Given this list of marker genes CANX, TACC1, ARNT, DSCAML1, PTPN12, PRTG, ELOVL3, ZIC2, CKS1B, DNAJA2, MORF4L2, DPYSL3, MMD, PRRG1, SRSF7, DMWD, ELOVL5, NEXMIF, ZNRF2, ATP10A, NAALADL2, DENND6A, FOXJ3, NBEA, ANKRD50, SIPA1L3, NSG2, ZZZ3, ARHGAP5, GPRC6A, LMO1, SHTN1, JAKMIP2, HAPSTR1, H3-3B, NF2, NHLH2, ACACA (NCBI Gene Id 31), NUTF2, GRIK2, SYNE2, WDR44, MYLK4, POU3F2, UBP1, JUND (NCBI Gene Id 3727), HTRA1, ADAMTS6, NADK, PCOLCE, YTHDF2, EIF5A2, NEUROD1, FBXO11, SZRD1, H3-5 (NCBI Gene Id 440093), STAC2, FUT8, H3-3A, CLK1, WAPL, SON, RBM4B, CACNA1C, SLITRK2, AGO4, BEND4, IGF2BP1, FGFR2 (NCBI Gene Id 2263), C5orf24 (chromosome 5 open reading frame 24), ELF2, PPP1R21, KMT2A, BMPR2 (NCBI Gene Id 659), NOVA1, PCSK1, ADAM10, RNF20, DMD (NCBI Gene Id 548327), CLTA, TACC2, RB1CC1 (RB1 inducible coiled-coil 1), UBFD1, OGT, SP4, ADAMTSL3 (ADAMTS like 3), SLC26A3, ARID4B, ELP1, PHOX2B, CYSTM1, OSBPL6, PRP4K, SMARCE1 (NCBI Gene Id 6605), SETD7, SZT2, RAP1B, EGR3, TAC1, ARHGEF17, LRRC19, LUC7L3, TLNRD1, PRICKLE2, ZNF207, BHLHE40, HAS2, CDK12, WWC2, ANKHD1, CCND2, SGMS1, TMED2, CELF2, LANCL2, DBN1, PTER, CUL4A, BMAL1, RBM39, ARHGEF12, GABRA5, HMGCS1, CERS6, CGGBP1, SFSWAP, FOXJ2, EBF3, ZRANB3, VPS26B, EIF1B, ING3, TMEM255A, IRF2BPL, PHF8, LRP1B, CHD9, HOXB5, PITX2, MBD5, TGIF1, PURB, PPARGC1A, UBE2K, MYLIP, ANKS1B, LIF, SLC25A16, DCBLD2, UNC45A, ATRX, ZC3H12B, LMX1A, AGO3, API5, SSX2IP, TRPS1, GALNT7, CNIH1, CAMK2D, LCOR, ATF3, ZNF281, EIF5, here is a description of the gene set: species: Homo sapiens Human Gene Set: ATGTTTC_MIR494 Genes having at least one occurence of the motif ATGTTTC in their 3' untranslated region. The motif represents putative target (that is, seed match) of human mature miRNA hsa-miR-494 (v7.1 miRBase).